The following is a description of a gene set: Genes predicted to be targets of miRBase v22 microRNA hsa-miR-4298 in miRDB v6.0 with MirTarget v4 prediction scores > 80 (high confidence targets). from publication Chen Y, Wang X (PMID 31504780) Human Gene Set: MIR4298 species: Homo sapiens, and this is the list of marker genes: NAA30, CEP20, NEDD1, SPIDR, DOCK3, STMN1, PGM1, SYT10, UBA6, LIX1L, ARHGAP32, ATL2, ING2 (inhibitor of growth family member 2), PECR, SHPRH, ARID5B, ZRANB1, MDN1, MINDY3, SLC36A4, TRAM2, COL4A3, ITGAE, UMPS, ZNF736, FKBP7, TMEM132B, NEXMIF, ENSG00000255537, KCNB1, YWHAZ, GMEB1, PPM1F, TRPS1, SMAD2, CTBP2, ESR1 (estrogen receptor 1), PLAAT2, CELF1, SKP1 (S-phase kinase associated protein 1), PTK2B, TASOR, GCSAM, RASL10B, LIAS, RUSC1 (RUN and SH3 domain containing 1), RAB23, ALDH5A1, C11orf58, CSGALNACT2, ONECUT2, PER1, TIPRL, LHX6, TM6SF1, SEPTIN3, RNF4, CDK19